Given this list of marker genes Bax, Atp12a, Bak1, Slc22a1, Atp1a1, Atp1a4, Atp1a3, Atp1b1, Atp1a2, Fxyd2, Cpox, here is a description of the gene set: Mouse Gene Set: GOBP_ESTABLISHMENT_OR_MAINTENANCE_OF_TRANSMEMBRANE_ELECTROCHEMICAL_GRADIENT species: Mus musculus The directed movement of ions to establish or maintain an electrochemical gradient across a membrane by means of some agent such as a transporter or pore.